Given this list of marker genes WASL, LINC00662, NR4A3 (NCBI Gene Id 8013), MED28, GKAP1, IL7R, FTX, ARRDC2, RB1CC1, HEXIM1, ZNF350, RNPC3, PLXND1, MGAM, GNS, TRIM23, AMN1, ZFP36, LYZ, MAT2B, FCHO2, SH3KBP1, ZNF354A, HSPBAP1, CSTA, ZNF106, TULP4, LINC00528, NSD1, MED13, MBTD1, BTG1, RGS2, ZFP36L2, DUSP2, YPEL5, APC, RALA, PPBP, FBXL20, ZEB2, SAT1, MARF1, HERPUD2, EIF4B, BEX3, PSMA3-AS1, CXCL8, ZNF644, RNF19A, ZBTB10, ZNF217, PCMTD2, YPEL4, SIPA1L3, CIR1, ZMYM2, OTUD1, MTSS1, SNX16, ATP2B1-AS1, NRIP1, VEZF1, SKIL, PDE3B, PNISR, NCF2, SQSTM1, TET2, ATM, NLRP3, KYNU, CTDSP2, RPL31, CAMK1D, RAB11FIP2, TCP11L2, KCNMB4, SIRT1, RABGAP1, CSNK2A2, TGIF1, TNFAIP3, TMEM260 (NCBI Gene Id 54916), MKRN1, SORL1, UBL3, ZSWIM6, THBS1, PFKFB3, SGMS1, APLP2, ATXN7L1, RSBN1, SERINC1, UBXN7, ASAP1, DIP2B, PNPLA8, PIK3IP1, ZNF565, TMEM43, TCF7L2 (NCBI Gene Id 6934), PAIP2, DAB2, ATRX, KDM7A, ATP2B1, ARAP1, SPEN-AS1, TSPYL1, TAPT1-AS1, NAMPT, SRGN, N4BP2L2, SOX4, FRAT1, NAA50, KMT5B, IFNGR1, RPL30, TECPR2, PLAUR, SNRPN, LITAF, ZHX2 (NCBI Gene Id 22882), WDR19, SMAP2, RGCC, WDR45, APPBP2, NBR1, ZFYVE16, SLC26A11, DUSP1, PAN3-AS1, AKT3, OGFRL1, FTH1, BCL6, RESF1, UBXN6, MARCKS, FAM228B, CD44, ZFYVE1, MED13L, ZC3H10, FOXO3, FHL3, EAPP, SOCS5, IRF2BP2, RAB21, RNF11, ARID5B, ADM, MAP3K2, DDX5, CXCR4, HBP1, CLK4, BBS1, BOD1L1, UBE2B, UNKL, CFLAR, BAZ2B, BACH1 (NCBI Gene Id 571), EFHC1, AOAH, JMY, FTH1P5, NORAD, DUSP22 (NCBI Gene Id 56940), ZBTB18, THEMIS2, UBN2, ERBIN, BTN3A3, KPNA1, LINC02035, CANX, PICALM, PRDM2, HOMER1, PNRC1, RPL27A, SCAF4, MIR101-1, PIK3CA, EPHA4, CBX7, PI4K2A, here is a description of the gene set: from publication Baram D, Dekel O, Mekori YA, Sagi-Eisenberg R (PMID 20190146) We demonstrate that the G protein Gi3 is the cellular target of the adenosine A3 receptor (A3R). By using a cell permeable peptide comprising the C-terminal end of Gαi3 fused to an importation sequence (ALL1) as a selective inhibitor of Gi3 signaling, we show that by coupling to Gi3, the A3R stimulates multiple signaling pathways in human mast cells, leading to upregulation of cytokines, chemokines and growth factors.Following contact with activated T cell membranes, endogenous adenosine binds to and activates the A3R, resulting in Gi3-mediated signaling. Specifically, the majority of ERK1/2 signaling initiated by contact with activated T cell membranes, is mediated by Gi3, giving rise to ALL1-inhibitable cellular responses. These results unveil the physiological GPCR that couples to Gi3 and establish the important role played by this G-protein in inflammatory conditions that involve adenosine-activated mast cells. We used microarrays to detail the effect of ALL1 on gene expression of HMC-1 cells activated directly by the A3 receptor, or by contact with activated T cell membranes. Human Gene Set: GSE19888_ADENOSINE_A3R_INH_PRETREAT_AND_ACT_BY_A3R_VS_A3R_INH_AND_TCELL_MEMBRANES_ACT_MAST_CELL_UP species: Homo sapiens Genes up-regulated in HMC-1 (mast leukemia) cells incubated with the peptide ALL1 followed by treatment with: Cl-IB-MECA versus T cell membranes.